Given this list of marker genes Rps6ka6, here is a description of the gene set: studied in species Mus musculus Reactome Pathway: CREB1 phosphorylation through NMDA receptor-mediated activation of RAS signaling electronically inferred by orthology from the curated human pathway This event has been computationally inferred from an event that has been demonstrated in another species.<p>The inference is based on the homology mapping from PANTHER. Briefly, reactions for which all involved PhysicalEntities (in input, output and catalyst) have a mapped orthologue/paralogue (for complexes at least 75% of components must have a mapping) are inferred to the other species. part of: Post NMDA receptor activation events